The following is a description of a gene set: Mouse Gene Set: MIR_6935_3P Genes predicted to be targets of miRBase v22 microRNA mmu_miR_6935_3p in miRDB v6.0 with MirTarget v4 prediction scores > 80 (high confidence targets). from publication Chen Y, Wang X (PMID 31504780) studied in species Mus musculus, and this is the list of marker genes: Nt5e, Mcf2l, Baz1b, Syne1, Arfgef2, Arx, Hapln1, Ikzf3, Zfp704, Kcnab1, Fndc8, Cntln, Nom1, Etv6, Gucy1a2, H2-Ob, Gpr180, Nlrc3, Cd86, Zfp960, Lgr5, Cdkn1a, Gata6, Qser1, Bcl6 (NCBI Gene Id 12053), Etfa, Zfp951, Tfr2, St3gal2, Lypla1, Ift81, Tcf12, Itga6, Kras, Eps8, Tfrc, Psme4, Rnf6, Vmn1r8, Pabpc2, Lama3, Zfand4, Hs3st3a1, Crls1, Syf2, Zfp1008, Rapgef6, Teddm3, Zfp462, Bcl11b, Pdhx, Gabpa, Onecut2, Prkrip1, Slco5a1, Fmnl2, 2210418O10Rik, Vps26b, Myo9a, Ep300, Cfap43, Lysmd2, Depdc1a, Matr3, Celf4 (NCBI Gene Id 81911), Elk3, Zswim6, Azin1, Foxf1, 0610030E20Rik, Bbs4, EU599041, Tectb, Casp12, Hyal4, Slc41a2, Srd5a1, Ino80d, Zfp966, Hus1, Zfp108, Dmtf1l, Dpcd (deleted in primary ciliary dyskinesia), Mpzl2, Plekha3, Ccnj, Map1b, Txn2, Ppp1r1c, Cdk12, Fpr1, Hnrnph2, Zfp384, Wwox, Wnt5a, Gramd4, Tmem54, Tex16, Rps6ka6, Aifm2, Mfsd14a, Thap2, Il1r1, Iqsec3, Kank2, Lrrc4, Tifa, Klhl31, Meis1, Sos1, Mageb5b, Grik5 (NCBI Gene Id 14809), Csnk2a1, Sem1, C1qtnf12, Setd2, Cops9, Ch25h, Grik2, Cgref1, Zfp120 (NCBI Gene Id 320490), Vmn1r71, Alg10b, Crisp2, Rnf113a2 (NCBI Gene Id 66381), Mlycd, Idh3a, Wdr7, Abhd18, Cdc7, Sema3a, Asb3, 5730507C01Rik, Ess2, Mylk4, Myo15a, Vps4b, Zfp1009, Potegl, Zfp967, Strbp, Zfp936, Nup62 (NCBI Gene Id 52394), Adamts1, Clint1, Eea1, Gja8, Ust, Taf13, Samd13, Zfp599, Nsun6, Etaa1, Fam243, Pdf (NCBI Gene Id 68023), Lrrtm2, Cacng2, Trpm3, Camta1, Blzf1 (basic leucine zipper nuclear factor 1), Lpar1, Nova1, Ptpn21, Tsc22d2, Ctdspl, St3gal5, Tulp2, Oaz2, Ttc39b, Slc38a9, Armh4 (NCBI Gene Id 67419), Creg2, Pdpk1, Als2, Lin28b, Zfp976, Npat, Zfp970, Stxbp3, Paxbp1, Akap12, Mettl21e, Cyp2c50, Mc3r (NCBI Gene Id 17201), Sel1l3, Kmt2d, Optn, Sprr2h, Gpd2, Trim32, Fsbp (NCBI Gene Id 100503583), Ppp2r5c, Vgll3, Pappa, Il22b, Gli3, Klhl29, Caps2, Marchf5, Vldlr, Gng2, Gm6712, Samd8, Cacna1a, Dop1a, Npy1r, Ranbp1, Nek4, Ttc3 (NCBI Gene Id 70444), Cd3d, Gjb6, Antxr1, Fbxo33, Mbnl1, Pik3r3, Scamp1 (secretory carrier membrane protein 1), Zfp935, Mrpl17, Il22, Adra1b, Dlat, Ebna1bp2, Entpd1, Miga1, Ddi2, Cdc5l, Pde1c, Pde4a, Gm7694, Fbrsl1, Slc4a4, Mybl1, Gm14296, Osbpl8, Dcaf1, 4833420G17Rik, Fam210a, Zfp800, 9530002B09Rik, Fn3k, Pla2r1, Zfp971, 4930558K02Rik, Creb5, Zfp97, Golga4, Gtf2h3, Cep135, Zfyve19, Acer3, Gabra1, Gpm6b, Tent2, Shtn1, Haus6, Rev1, Sh3bgrl, Star, Ehmt1, 5031439G07Rik, Ulk2, Capzb (capping actin protein of muscle Z-line subunit beta), Fam161a, Resf1, Dhx33, Rasgef1a, Ctsk, Arhgef12, Foxg1 (NCBI Gene Id 73022)